The following is a description of a gene set: Human Gene Set: NR1I2_TARGET_GENES Genes containing one or more binding sites for (NR1I2) in their promoter regions (TSS -1000,+100 bp) as identified by GTRD version 20.06 ChIP-seq harmonization. from publication Yevshin I, Sharipov R, Kolmykov S, Kondrakhin Y, Kolpakov F (PMID 30445619) species: Homo sapiens, and this is the list of marker genes: RPS19BP1, CKAP2, GTF2A2 (general transcription factor IIA subunit 2), ASNS, SLC2A1, PARP6, ASXL2, EMC9 (ER membrane protein complex subunit 9), TMT1B, PRH1, DHCR7, UBE2H-DT (NCBI Gene Id 121832803), FBXL5, LRRC14, EBAG9, ANXA2, DDX23, SLC9A4, TMEM39A, FAR1-IT1, PAGR1, PTRHD1, RNMT, ASAH1-AS1, MRRF, MCMBP, CTSH, AMACR, PPIA, NFIX, SNORD25, SIM2, PTPN23-DT, AK2, GANC, TP53BP1, IL5, TECPR1, AGPAT1, BNIP2, COX18, FAM187A, ACAD10, LSM8, RPLP1, LNCATV, NUP214, DNAJB12, STOML2, CCAT2, ATP5ME, CDCA3, RN7SL525P, REEP5, PPAN, ALDH2, LACTB, GARS1, LINC02029, PUS1-AS1, TRIM28, ZNF609 (zinc finger protein 609), RNU12, ZBTB4, LINC01671, WAPL, SAYSD1, UBQLN1-AS1, ESYT2, SPEF2, TMEM14A, SELENOH, AGPAT3, AHNAK, RNU6-92P, LINC-PINT, DMAP1, HINFP (NCBI Gene Id 25988), LPCAT4, ATP5MC2, TMEM131, TNFAIP8, THUMPD3, DGKA, STN1, RAD51, SMIM30, PRR4, LENG9, DAGLB, HYAL3, MPI, RPS27L, RN7SKP193, CCDC103 (coiled-coil domain containing 103), MEST, COPZ1, MAPKBP1, NAT10, ETFA, SNHG21, INTS14, ARL6IP1, ENSG00000241525, VPS13B-DT (VPS13B divergent transcript), IDNK, PRANCR, AGBL5, CRAT, YEATS2, ADPGK-AS1, CFAP68, NAA80, AP2B1, TRBV8-2, VPS45, RPS6KB1, SLC12A9-AS1, AP2A1, RHNO1, RAP1A, SEC23IP, IFNAR1, CXXC1, USP5, NME1, CHMP3, MTCH2, RAB5IF, LARP4, TMC3-AS1, MRPS21, POLR2M, TMEM87A, FAM114A2, EIF3J-DT, PRDM4, RNF6, ZFYVE27, SLC12A9, DHCR7-DT, SIN3A (NCBI Gene Id 25942), PAICS, NBN, MAN2C1, CYB561D2, MHENCR, ASAH1, RBM22 (NCBI Gene Id 55696), UBE3A, EIF2AK4, KMT2E-AS1, PEX5, RACGAP1, DDX39A, RHOA, TAS2R14, MIR1284, LNCTAM34A, PPAN-P2RY11, RBM17, ZC3H14, HOMER1, RBM33-DT, DPP8, RAD50, TOMM7, MAP3K5 (NCBI Gene Id 4217), FEN1, MARCHF3, ZNF250, CEP85, FBXO42, NFE2L3, SFR1, NCBP2AS2, ACAT2, NUP205 (nucleoporin 205), PLAUR, SGO2, SLC12A2, CLN6, SLC24A1, GPA33, SLC25A12, BUD31, SLC37A3, MRPL11, KLHL35, CPSF7, POLR2A, RAB7A, FAM210A, FDXACB1, ENC1, EIF2B5, NAP1L4, MAPKAPK5, VDR, HEXA, DDR1, ARMH3, SLC3A2, CSRP2, AGBL5-AS1, C2CD4A, CDK12 (NCBI Gene Id 51755), DNAAF10, SIRT2, MAPKAPK5-AS1, EIF2B5-DT, ANG, ASCC3, CYP51A1-AS1, ABCC3, ENO1, GTF3C6, SNORD26, EFTUD2, ALCAM, RETREG3, CCNI2, PNO1, SCARB1, TCTA, KCTD21, FOXM1, PPM1K, DNAJC2, CASD1, EFCAB5 (NCBI Gene Id 374786), MLST8, LIAT1, FBXO38, TOPBP1, UACA, ITFG2-AS1, RAPGEF6, FAM200B, SLC12A2-DT, DR1, HMGCR, C5orf34, NPRL2, DIP2A, TPM1, USP45, AMPD2, RBM33, SHC4, UBE2M, LIMA1, HEXA-AS1, SRGAP1, HIPK1, H2AZ2, OSBPL2 (NCBI Gene Id 9885), HBP1, IMPDH1, BOK, EPS8, H2AZ2-DT, MYL5, PDAP1, GTF2H4, NCBP2, UBE2H, CHCHD3, C12orf60, SLC38A1, SNHG1, EEF1A1, TUBD1, ATMIN, MEPCE, SNRPCP3, SLC20A1, HIPK1-AS1, POU2F1, VPS26B (VPS26 retromer complex component B), NRGN-AS1, SNRNP35, TULP3, PCBP1-AS1, RIMOC1, EID1, TUFT1, CCDC107 (NCBI Gene Id 203260), DDX21, PPAT, SLC6A9, PUS1, MIR4727, TIGD4, YBX3 (NCBI Gene Id 8531), TUBG1, ADPGK, NCAPD3, KANSL1, RN7SL1, SAP30BP-AS1, BRI3, LLPH-DT, CCNT1, MFSD5, UBQLN1, PSMB7, ASB7, GAS5, NAXE, POLDIP3, SLC35E3, SNORA9, CLN5, RAB18, FAM135A, PSMC2, EIF3J, PTPA, PEX6, COA4, XRCC6, HEXIM1, DLL4, INO80, KMT2E, RPS29, EIF4E, ARPC1A, ERVK3-1, NLN, DESI1, MRPL36, ZCWPW1 (NCBI Gene Id 55063), MFAP3, ARIH1, RPL8, GMEB2, MYG1, COPS7A, MIR4482, USP35, CCDC15 (coiled-coil domain containing 15), ITFG2, KDM1A, RNASE4, PABPC1 (poly(A) binding protein cytoplasmic 1), HSP90AB1